Given this list of marker genes MECP2, here is a description of the gene set: Missense mutations in the methyl-CpG binding domain (MBD) of MECP2, spanning amino acids 90 to 162, negatively affect the binding ability of MECP2 to hydroxymethylated DNA. Reactome Pathway: Loss of MECP2 binding ability to 5hmC-DNA part of: Loss of function of MECP2 in Rett syndrome species: Homo sapiens